The following is a description of a gene set: EPH-ephrin mediated repulsion of cells Mouse Gene Set: REACTOME_EPH_EPHRIN_MEDIATED_REPULSION_OF_CELLS species: Mus musculus, and this is the list of marker genes: Lyn, Rac1, Psen1, Fyn, Ephb1, Ephb3 (NCBI Gene Id 13845), Epha7, Efnb3, Epha10 (NCBI Gene Id 545678), Efnb1, Efna1, Ncstn, Epha4, Efnb2, Efna4 (ephrin A4), Aph1a, Ephb6, Psenen (NCBI Gene Id 66340), Efna3 (NCBI Gene Id 99908), Efna5, Ephb2, Vav2, Epha8, Epha6, Yes1, Vav3, Ephb4, Src, Epha1, Epha2, Aph1b, Mmp9, Efna2, Mmp2